The following is a description of a gene set: from publication Xie X, Lu J, Kulbokas EJ, Golub TR, Mootha V, Lindblad-Toh K, Lander ES, Kellis M (PMID 15735639) studied in species Homo sapiens Genes having at least one occurrence of the highly conserved motif M23 TAATTA in the regions spanning 4 kb centered on their transcription starting sites. This matches the VSX1 transcription factor binding site V$CHX10_01 (v7.4 TRANSFAC). Human Gene Set: TAATTA_CHX10_01 Comprehensive identification of all functional elements encoded in the human genome is a fundamental need in biomedical research. Here, we present a comparative analysis of the human, mouse, rat and dog genomes to create a systematic catalogue of common regulatory motifs in promoters and 3' untranslated regions (3' UTRs). The promoter analysis yields 174 candidate motifs, including most previously known transcription-factor binding sites and 105 new motifs. The 3'-UTR analysis yields 106 motifs likely to be involved in post-transcriptional regulation. Nearly one-half are associated with microRNAs (miRNAs), leading to the discovery of many new miRNA genes and their likely target genes. Our results suggest that previous estimates of the number of human miRNA genes were low, and that miRNAs regulate at least 20% of human genes. The overall results provide a systematic view of gene regulation in the human, which will be refined as additional mammalian genomes become available., and this is the list of marker genes: FCHSD1, SEMA4G, COL4A5, SFXN2, MTUS1, PHOX2B, RGS8, FIP1L1, NOTCH2, SEMA3A, TP53BP1, FZD10, TSPAN8, HAPLN1, ARFGAP2, TBR1, RHBDL3 (NCBI Gene Id 162494), CHRNA2, MYBPC1, IL17A, PGRMC1, PCDHA6, NKX2-1, CAB39, MIR137HG, NEBL, MAP2K7, MED12, ARHGAP26, SRSF7, MARCKS, ARPP21, MEF2C, STARD13, CNPPD1 (NCBI Gene Id 27013), CASK, UBAP1, CHL1, TTC39C, ZFAND6, RASA2, ENTPD1, ADAMTS10, PSMC6, MAX, RBFOX1, TMEM87A (transmembrane protein 87A), FTHL17, SPRY1, LYSMD2, SLC5A12, NTRK1, RFX3, TBC1D20, TXLNG, ARHGEF38, PCSK2, ELP4, RAB5B, ATP5MC1, PMEPA1, ANKRD1, ITPR3, KCNMA1, STAG3, FAM89A, HTR7, TMTC2, RWDD3 (NCBI Gene Id 25950), PAX3, PPP2R2B, LMX1A, FAM169BP, LIMS1 (NCBI Gene Id 3987), SLC9A5, IFI16, MECOM, HHIP, RPA2, CDAN1, ALKBH5, FUNDC1, NPVF, ACADSB, CGA, PAQR9, DIXDC1 (DIX domain containing 1), PCNT, SHOX2, DEDD, SERPINC1, YRDC, JDP2, NMT1, PART1, LRRC15, LY6G6E (NCBI Gene Id 79136), DLX1, LURAP1L (NCBI Gene Id 286343), SOBP, ANXA10, FILIP1, ZMIZ1, WDPCP (WD repeat containing planar cell polarity effector), ARC, COL1A1 (NCBI Gene Id 4970), ZC3H7A, PXDC1, NEUROG1, SLC44A3 (NCBI Gene Id 126969), DIP2B, DSG1, SKIDA1, TAAR5, DLX2, MYO1C, RBFOX2, KLHDC10, PITX1, TGM3 (transglutaminase 3), FLRT3, TFAP2D, FOXN3, HDGF, NXPH1, BACE2, ERBB4 (NCBI Gene Id 2066), PROK2, COL10A1 (collagen type X alpha 1 chain), BACH1, MYF6, CDH10, PITPNM2, CD36, GNAS, ETS2, TMEM182, TMEM169, ETV1, MITF, COPS7A, FOXF2 (forkhead box F2), NDP, CNTLN, MLLT10, LRFN5 (NCBI Gene Id 145581), SFN, OVOL1, FAM53C, STC1, ADAMTS17, NKX2-2, TMSB4XP4, NRL, CA4, VPS45, DMD, PITPNC1, STAT5B, S100PBP, IL1RAPL1, TSC22D3 (NCBI Gene Id 64477), MYBPC2, THRA, AQP3, GTPBP1, FIGN, SMOC1, ZBED3, ETNK1, PRKCH, SGMS2, KIF2B, ROBO3, FAM27E5, PDCD4, RNF39, DNAJB8 (DnaJ heat shock protein family (Hsp40) member B8), URI1, ARHGAP44, GJD2, XYLT2, CCDC9B, PACSIN3, TFDP2, LTBP3, SP6, FEZF2, TRIM24, FST, PPP2CA, CLDN4, PRR34, EPHB2, EOMES, NUP35, ZIC1, ATP11C, SLC24A2, PMF1, JCHAIN, ZEB2, GPX1, KRT25, PLPP3, CAPN7, SSBP3, MSRB3, WIF1, CTNND1, STXBP3, MAB21L2, BASP1, ACTR10, TM2D2, TYR, PRKAR2A, CITED2, NEO1, NDNF, EN1 (engrailed homeobox 1), SMARCA2, ENSG00000291228, PLAU, CLSTN2 (NCBI Gene Id 64084), CPA5, LRP2, PNMA1, SUCLG2, DLL4, CCNG2, CORO6, SFRP1, DNAJB4, FOXP2, BHLHE41, SLCO5A1, KMT5C, OPN3, ATP2A2, SCRT2, TMEM67, NCKAP5, EFNA1, TAGAP, LMO3, ST8SIA3, ARL2BP, GPC2, VWA7, GGNBP2, TNRC6A, C8A, IMPG2, HOXB7, HOXC4, SALL1, KLF14, RPP25, TBX19, ZDHHC12, TYRO3, AP1G1, ERO1B, FOXG1, CADM2, NRP1, KIRREL3, HRK, PLPP1, CDH6, NPR3, MED24, ELMO2 (engulfment and cell motility 2), ZNF385B, LIX1, PSD3, CPEB4, CLK2, PAX2, ADAM11, GAP43, OCLN, DCN, CRYBG2, VWF, BAMBI, YES1, ARHGAP6, SECISBP2L, ELAVL2, CANX, SMAD6, AFP, SERPINB7, TFAP2A, MSX1, RORB, ZFHX4, BARHL2, ADARB2, ZNF488, PGR, PKP3, TAC1, BARHL1, PJA1, CDO1, POPDC3, RCAN1, PRDM8, OGN, LMO1, XPOT, WNT3A, AP1S2, CNN3, MYT1, JPH3, KRT222, TMSB4XP1, DSPP, SEZ6, SLC7A9, OGT, LAMB1, ARL3, INVS, CYTH3, MCTS1, IRX2, GAS2, AIG1, IRX2-DT, PTCHD4, MS4A1, PBOV1, FOLR1, NKX6-1, ACE2, TSPAN7, MYH2 (myosin heavy chain 2), MPC2 (NCBI Gene Id 25874), SLC13A1, EIF5A, ONECUT2, MED12L, RARB (NCBI Gene Id 5915), BAIAP2L2, DHX38, PDLIM1, MEF2B, IER3, SEMA5B, CLDN17, SLC26A7, TACSTD2, RAB40A, MSX2, OTOP3, LRP5, WT1-AS, KRT74, CDKL5, JADE1, PPFIBP1, HESX1, CLIP4, WIPI1, AAK1, CACNA2D3, PIK3R3, HAUS2, CALR, ELAVL4, PPP1R13B, CMTR2, GPR157, GPR15, DAAM2, KCNQ1DN, SESN2, EXOC5, PRDM1, ZIC4, CBLB, HABP2, HMGN2, BNC2, MTSS1, PRMT5, ATP5MC2, ARRB1, FAP, PTPRO, TMEM179, MYH8, NLGN2, HCRT, SP8, MAP1B, VAMP8, COMMD10, TMIGD1, OFCC1, TMEM178A, TECTA, NOTCH2NLA, NABP2, RASL11B, HOXA4, OPRM1, BTBD3, INKA2, RAB6A, ARID3B, TNFSF13B, PTH1R, HERPUD2, MYH4, TMSB4XP8, MIR9-1HG (MIR9-1 host gene), RGS12, FZD2, ESR2, INPPL1 (NCBI Gene Id 3636), OSR2, OTP, RPIA, CHD2, MFSD14CP, UBR3, PPM1E, OTX2, CDIN1, JHY, FIZ1, KRT23, ARHGEF10L, SALL3, CNTN4 (contactin 4), BEST3, DCAKD, GEN1, ROBO1, RTCB, SLITRK5, PCNX1, HTN1, PURA (purine rich element binding protein A), EREG, LINC03122, KCNH5, TRPM8, RREB1, SEMA7A, ITGA10, RTN4RL1, YPEL4, CYYR1, SOHLH2, ARHGEF2, MMP20, CA2, OTUD7B, PIP4K2B, MPPED2, PALS1, HOXA2 (NCBI Gene Id 3199), POGZ, CCNG1, VPS13D, DLC1, STMN2 (NCBI Gene Id 11075), WNT8B, SH3BGRL2, SEZ6L, BDNF, APPL2, SLC37A4, ZBTB9, PECR (peroxisomal trans-2-enoyl-CoA reductase), TMSB4XP6, WHRN, CACNG2, SIX3, SERPINB11, HOXA11, C1orf87, TRDN, RAPGEFL1, PLXNA2, CDYL, CALD1 (NCBI Gene Id 800), SLITRK3, LRRTM1, TUBB6, ERG, AGAP3, C5, CDC42EP3, BMP4, NAALADL2, RUNX1T1, LRRC57, SSPN, RP1L1, IKZF5, C22orf31, ITGB3BP, LIN28A, UBE2E4P, EGFLAM, HOXB4, ZDHHC21, CALN1, NOL4L, OGG1, ELMO1, PPP1R14C, FGF19, PDZRN4, EPHA2, EPB41L3, SLITRK2, PRRX1, PROP1 (NCBI Gene Id 5626), RASL10B, BMAL1, PDC, POU3F4, BMPR1B, CTNND2, ALK, SGPP1, SI, ZBTB20, CYFIP2, BACH2, HOXC12, LAMC1, CACNB3 (NCBI Gene Id 784), STAC2, PAK1IP1, OSER1, NPAS2, ETV3, MYO1B, CLRN1, RAX, KRTAP11-1, CYLD, PLEKHA6, ZNF366, PPP1R16A, FEV, ZFP36L1, ANKS1B, PHTF2, CEP41, ZCCHC13, ELP2, KRTAP8-1, TXNL4B, SIAH3, MRPL3, C1QA, WNT5A, KAT6B, THADA, TAL1, PRKAB1, TSGA10, SMURF2, APLF, TMPRSS11D, STAG2, AMFR, DPH1, MAP3K20, TAOK2, C2orf15, STAC, ITGA8, TMCC1, TBC1D21, LOXHD1, LEMD1, RORA, TUBB4A, KCNK2, COL11A2, NTNG2, DMRTA1, BCL6, SOCS5, ADAMTS13, SMAD1, FAM193B, FUT8, MBNL1, FRA10AC1, VLDLR, NFYA, GBX2, AMD1, CEP120, PPP1R1B, GPR22, ALPK2, ENAH, SULF2, TLE4, UNC5B, SUPT3H, ASPHD1, DSCAM, GARRE1, SULF1, HOXA5, H1-2, FEZ2, CADM1, LPAR4, NOL4, MOSMO (modulator of smoothened), MMP27, LINC00314, DDX6, PRODH2, PTPN21, SNTG1, ARHGDIB, DSCAML1, ATP6AP2 (NCBI Gene Id 95880), LUC7L3, GNB2 (G protein subunit beta 2), OSBPL8, NFIX, RNF122, LINC00303, ARHGEF7, CDH20, GRHL3, MUC15, PELI2, FLOT1, RIPK4, HS3ST1, EDEM1, EDC4, DNASE2B, LIPC, PDE1A, BAZ1A, AFF3, RFXANK, ARL5B, SYNE2, U2AF2, GNA13, SORBS2, TMSB4XP2, REEP4, DSG4, AP5M1, KCNN3, HAS3, NREP, DCX, CDKN2C, NELL2, STX7, PRL, PDE7A, NEUROD1, LGALS12, NR2F1, SOX5, FZD7, STAT3, LINC01164, DPY19L3, ELF4, GNAO1, SP7 (Sp7 transcription factor), PAX6, LBX1, ITGBL1, PCDHB15, AKTIP, WAPL, GSE1 (Gse1 coiled-coil protein), PRKAG1, CHST8, KLHL4, TP63, NOVA1, LRRC4, TMEM94, MAB21L1, MYL1, GPC3, TFEC, BMP1, GARIN1B, SERINC2, NIM1K, UBXN10, H2AZ1, KRT73, GTF2B, MID1, HPGD, CCDC149, DAB1, MNT, LCOR, SLITRK1, SLC6A5, NDST4, SLN, EYA1, TBX6, FYN, COL12A1, POMC, DPP10, ADD3, C1orf122, PDGFRA, POU2F1, ACBD5, ZRSR2, FKBP5, STK3, TAFA1, PITX2, SLC7A11, IRX4, IL13RA1, PRPF38B, DDX17, PENK, HNF1A, NFIL3, KCTD15 (potassium channel tetramerization domain containing 15), SPAG5, RPA3, GPR65, DLGAP4, NEK10, TMEM117, HTR2C, GRHL1, KCP, TGM6, ZNF423, CELF2, KRTAP19-6, DENND1B, TUBB, CHST10, TLL1, NOX3, IFT70B, ASCL4, MSTN, SOAT1, EMX2, POLR3GL, MYH1, SIX1, GRM8, KRT32, ZNF524, OLFM4, LMO4, LINC01597, LHX6, SSH2, KLK13, SERTAD4, IMMP1L, TMEM185A, HOXC10, HPCAL1 (hippocalcin like 1), GPRC5C, CKM (NCBI Gene Id 95741), CDH19, KDM6A, RFTN2, CS, ETV6, REEP3, ADAM9, SRPK2, BLMH, DACH1, CGN, SLC39A6, BMPR2, CARMIL1, ATXN7L1, PCDH18, KALRN, ACP6, EDA, LDB2, OARD1, CREB5, WNT7A, PCDHB3, PBX2, ZBTB18, FBXO40, ATP2B4, IRX5, MORC1, NDUFA4L2 (NDUFA4 mitochondrial complex associated like 2), MIA2, ID2, GJB6 (NCBI Gene Id 1897), IRX6